The following is a description of a gene set: Activation of NF-kappaB in B cells Human Gene Set: REACTOME_ACTIVATION_OF_NF_KAPPAB_IN_B_CELLS species: Homo sapiens, and this is the list of marker genes: PSMC4, NFKBIB, MALT1, PSMA6, PSMD8, PSMB4, PSMA4, PSMA1, MAP3K7, PSMC3, NFKB1, PSMD14, PSMC5, PSMA5, BTRC, PSMB3, PSMC1, PSMA7, IKBKG, PRKCB, PSMB1, ADRM1, CHUK, UBA52, FBXW11, PSMD1, PSMD7, SEM1, PSMD11, REL, NFKBIA, CARD11, PSMB7, RELA, NFKBIE, PSMB6, BCL10, PSMD2, PSMC2, PSMB5, RPS27A, PSMD12, PSMD6, PSMD3, PSMC6, IKBKB (inhibitor of nuclear factor kappa B kinase subunit beta), CUL1, PSMD13, UBC, UBB, SKP1, PSMA3, PSMB2, PSMA2